Given this list of marker genes VPS35, DRD2, NOS1, GAS2L2, PHB1, MIR1-1, KLK6, EDN1, PDE6G, F2, MRAP, NRXN1, PTGDR2, DRD3, MRAP2, TREM2, PDE6H, POMC, CHGA, C3, GPR27, CCL5, GPER1, CNTN2, CAV2, APP, PKD2 (polycystin 2, transient receptor potential cation channel), TMOD2, FGF8, ACP3, LRRK2, HIF1A, KLK14, PRKCA, KLK5, RGS2, GSK3A, PRMT5, NECAB2, ITGB3, SLC39A14, GRP, here is a description of the gene set: studied in species Homo sapiens Human Gene Set: GOBP_POSITIVE_REGULATION_OF_G_PROTEIN_COUPLED_RECEPTOR_SIGNALING_PATHWAY Any process that activates or increases the frequency, rate or extent of G protein-coupled receptor signaling pathway activity.